The following is a description of a gene set: studied in species Homo sapiens Catalysis of the cleavage of C-C, C-O, C-N and other bonds by other means than by hydrolysis or oxidation, or conversely adding a group to a double bond. They differ from other enzymes in that two substrates are involved in one reaction direction, but only one in the other direction. When acting on the single substrate, a molecule is eliminated and this generates either a new double bond or a new ring. Human Gene Set: GOMF_LYASE_ACTIVITY, and this is the list of marker genes: CLYBL, AZIN1, GNAZ (NCBI Gene Id 2781), CYP1B1, KYAT1, ENOSF1, ACO2, CA4, LTC4S, SHMT1, ALAD, NPR1, ENO4, OGG1, GUCA1C (guanylate cyclase activator 1C), PCK2, OAZ2, GNAS, HADHB, CSAD, DGLUCY, ACMSD, ADCY10, DDC, UROD, ECHDC1, RCVRN, CRY2, ECHDC2, GUCY2F, APIP, KYAT3, GUCY1A1, POLB, CYP2S1, MOCS1 (NCBI Gene Id 7931), NHERF4, CA6, CENPVL3, PLPP6, NEIL2, ILVBL, NCS1, FTCD (formimidoyltransferase cyclodeaminase), PCBD2, MLYCD, HMGCLL1, ECHS1, ACCS, HSD17B4, NPL, GADL1, RNASET2, ETNPPL, RGS2, HAL, HTD2, GUCA1B, ALOX12B, GSTM4, ME3, CA5A, AUH, HACD2, DERA, ADCY5, PHYKPL, ENO3, TGDS, TYW1B, ADSL, GLDC, GGCT, GUCA1A, GOT1, PM20D1, PTS, CA5B, TSEN34, ADCY3, GNAI1, NEIL3, NAXD, AMD1, THNSL2, CALM3, CA10, TSEN2, PISD, SHMT2, FH, GNAO1, HMGCL, ENDOU, HMGB1, NTHL1, PDXDC1, PDXDC2P-NPIPB14P, SDSL, ASL, AZIN2 (NCBI Gene Id 113451), CA2, PTGIS, TBXAS1, CBS, PAICS, RNASE2, CYP1A1, FAHD1 (fumarylacetoacetate hydrolase domain containing 1), HACL1, UROS (uroporphyrinogen III synthase), GAD2, CA1, CD38, CA12, ENSG00000274276, ME1, CYP17A1, CYP1A2 (NCBI Gene Id 1544), CA9, CA8, HMGA1, ENO1, GUCA1ANB-GUCA1A, PCBD1, GUCA2A, ACO1, SCLY, CA5BP1, RPS3, CHAC1, TPI1, URAD (NCBI Gene Id 651560), UROC1, ALDOA, GUCY1A2, HDC, CA13, ARMT1, BCKDHA, CHAC2, HACD1, ODC1, ALDOC, CENPV, GRM7, USB1, ALKBH1, CALM2, ADCY6, ADCY9, GUCY1B1, UMPS, GLO1, PARK7, ECHDC3, CALM1, GUCA2B, OAZ3, GGACT, MVD, HACD3, FECH, TKFC (triokinase and FMN cyclase), PTGES2, MGST3, FASN, HCCS, ADCY7, ADCY4, SDS, ALDOB, CDYL, COQ4, HMCES, ACOD1, NPR2, MGST2, RAF1, ADGRV1, SGPL1, UXS1, GGCX, PAM, IREB2, CENPVL2, GNAL, ALOXE3, ALOX5AP, L3HYPDH, ENO2, SRR, ADCY2, GATD1, CRY1, OAZ1, RSAD2, HADHA, CA14, GUCY2C, BST1, TYW1, ADCY1, HOGA1, GMDS, EHHADH, POLL, MOCOS, GAD1, CA7, HACD4, ADCY8, GUCY2D, CENPVL1, HMGA2, PPCDC, XRCC6, XRCC5, CA3, POLG, NEIL1, RNASE1, DDTL, DDT, PCK1, ME2, CTH, CA11 (carbonic anhydrase 11), POLQ